Given this list of marker genes Calm2 (NCBI Gene Id 75700), Calm1, Phpt1, Micu1, Ywhae (tyrosine 3-monooxygenase/tryptophan 5-monooxygenase activation protein, epsilon polypeptide), Itpr1, Tnni3, Mcub, Fkbp1b, Slc30a1, Calm3, Stx1a (NCBI Gene Id 20907), Pacsin3, here is a description of the gene set: Binds to and stops, prevents, or reduces the activity of a calcium channel. Mouse Gene Set: GOMF_CALCIUM_CHANNEL_INHIBITOR_ACTIVITY studied in species Mus musculus